Given this list of marker genes Wipi2, Wdr45, Acbd5, Pik3r4, Wipi1, Wdr45b, Rb1cc1, Atg2a, Sqstm1, Pex5, Pjvk, Pik3c3, Pex2, Atm, Atg2b, here is a description of the gene set: The process in which peroxisomes are delivered to a type of vacuole and degraded in response to changing nutrient conditions. studied in species Mus musculus Mouse Gene Set: GOBP_AUTOPHAGY_OF_PEROXISOME